Given this list of marker genes Ly6c2, Chrna5, Gabra2, Gabrg2, Spdye4b, Gabrg3 (gamma-aminobutyric acid type A receptor, subunit gamma 3), Chrne, Gabrr2, Ly6m (lymphocyte antigen 6 family member  M), Grm5, Chrnb1, Grin1, Chrna6, Gabrr1, Gabrp, Ly6i, Gria2, Chrna2, Chrna1 (cholinergic receptor nicotinic alpha 1 subunit), Drd1, Htr7, Grik3, Gpr158, Gabre, Gria3, Drd2, Slurp1, Ly6g6g, Grik2, Ly6c1, Grik4, Ly6h (lymphocyte antigen 6 family member  H), Htr5a, Pate4, Ly6f, Chrnb2, Gabrg1, Gabra6, Lypd6, Kctd8, Grin2a, Grik1, Drd3, Htr1a, Ly6g6e, Drd5, Gabrq, Ly6g6d, Chrna3, Kctd16, Gabrb1, Glra2, Tspo, Grid2, Grin3b, Htr6, Chrna4, Chrna10, Gabrb2, Glra1, Tmem35a, Grik5, Chrm1, Hrh2, Gabra5, Grid1, Htr2c, Kctd12, Grin2d, Htr3b, Glra4, Chrm5, Lypd1, Chrnd, Htr5b, Ly6g, Spdye4a (speedy/RINGO cell cycle regulator family, member E4A), Ly6g2, Grin2c, Gabbr1, Chrm3, Htr3a, Hrh3, Chrnb3, Gabra1, Htr2b, Agrn, Ly6a, Chrm2, Htr1b, Psca, Hrh4 (histamine receptor H4), Htr4, Gabrd, Htr1f, Lypd6b, Grin2b (glutamate receptor, ionotropic, NMDA2B (epsilon 2)), Chrna7, Drd4, Grm1, Glra3, Slurp2, Gabrb3, Kctd12b, Chrnb4, Adrb1, Chrm4, Anxa9, Grin3a, Gabra4, Chrng, Lynx1, Cdk5, Ptk2b, Htr1d, Gria1, Gabra3, Ly6e (lymphocyte antigen 6 family member E), Chrna9, Htr2a, Gria4, Glrb, here is a description of the gene set: studied in species Mus musculus Combining with a neurotransmitter and transmitting the signal to initiate a change in cell activity. Mouse Gene Set: GOMF_NEUROTRANSMITTER_RECEPTOR_ACTIVITY